The following is a description of a gene set: studied in species Homo sapiens Human neuronal differentiation alters responsiveness to innate immune stimuli and virus infections. We used microarrays to examine the transcriptional responses of the human BE(2)-C neuroblastoma cell line to retinoic acid-induced differentiation and type I IFN stimulation. Genes up-regulated in mature neuron cell line: control versus interferon alpha (12h). from publication Peltier DC, Simms A, Farmer JR, Miller DJ (PMID 20483728) Human Gene Set: GSE16450_CTRL_VS_IFNA_12H_STIM_MATURE_NEURON_CELL_LINE_UP, and this is the list of marker genes: FAM227B, LRRC72, ZYG11A (NCBI Gene Id 440590), THEM6, PRAMEF2, TMOD1, NKX6-1 (NK6 homeobox 1), SCD, PDIA4, LRGUK, ADGRV1, BTBD2, CRIP3, ELF3, DPM3, FCER1A, SYT2, FNDC7, C17orf75, SLC17A7, MST1, NFE2L3, ADORA3, BBS9, EGLN2, C4orf36, PHACTR3, ATF6B, PPP1R1B, MAPK4, ELFN1, EFTUD2, SPIC, CZIB, COL14A1, ABCA2, ZNF398, CASZ1, GPBP1L1, CA8, PTPDC1, TMEM30A-DT, TSPY1, PTPRM (NCBI Gene Id 5797), ZHX3, ETV2, TFAP2C, GPR87, PTGER3, INSC, MEOX2, FAM163B, ZFP14, CFAP221, CELSR2, ZCWPW2, IGF1R, LY6G6D, ZNF282, MYO5C, INHBC, PPP1R26, CPN1, TSPAN17, DIPK2B, SOX1, NR1H2, ANK3, ATP12A, MPP2, MPZL2, TTC13, CCDC39, ZNF707, SOX7, ASB14, ACSM3, BCL2L1, RIBC2, SFI1, CHRNA3, RAPGEF3, ABHD8, GRB7, BSDC1, DUSP28, ACD, LYPD3, NOL3, IL1RL2, CLOCK, INSYN1, SLURP1 (secreted LY6/PLAUR domain containing 1), GPR158, FOXC2, ACOX2, DUSP18, FAM227A, LRRTM2, CTXN1 (NCBI Gene Id 404217), INS, LRIT2, GK2, PCNT, ZMAT5, QRICH1, HHAT, TMEM191C, CEP131, GAPDHS, KRTAP19-3, IGLL1, RGS9, MAPK8IP2, KBTBD4, CHIA, VTI1A, MATN2, CIMAP1B (NCBI Gene Id 91292), NXPH2, NEK2 (NCBI Gene Id 4751), UPP2, C10orf62, PACRG, UBXN11, RPL27, SLC39A2, APBB1IP, IGFBP3, HOXD4, SBSPON, GFAP, RIMKLA, KLC3, HSF2BP, MYOF, CHRNA5, RCBTB1, SGF29 (SAGA complex associated factor 29), GRIA3, INPPL1, TLE2, UBQLNL, GPR179, SNX20, CD79A, EPHB4, MTG2, NTF3, GNL2, PDXP, TMEM177, KCNQ1, RTKN, MFAP5, TRARG1, DNALI1, PDGFRL, SLC16A11, HES2, ACKR3, GIGYF1, GRAMD1B, TYRP1, PLCD1, GPR173, FAM20A, IGFBP7, SH2B2, TBCCD1, MYH11, TERB2, CYP1B1, LYRM1, COL25A1, IFFO2, SCTR, NAGA, GAN, IGFBP6, FOXD1, FAM229A, SGTB, WDR64, CCN4, GSC, SOX9, MN1, TMEM200A, PDHA2, CYP7A1, CCDC18, B4GALT6, CCL19 (C-C motif chemokine ligand 19), TBX19 (NCBI Gene Id 9095), AQP7, PRUNE1, DDO, ZFP1, PBLD